Given this list of marker genes Eea1, Snx9, Zfyve1, Mcf2l, Adap2, Picalm, Frmpd2, Zfyve16, Snx10, Epb41, Zfyve9, Snap91, Wdfy3, Wdfy1, here is a description of the gene set: Mouse Gene Set: GOMF_1_PHOSPHATIDYLINOSITOL_BINDING Binding to a phosphatidylinositol, a glycophospholipid with its sn-glycerol 3-phosphate residue is esterified to the 1-hydroxyl group of 1D-myo-inositol. species: Mus musculus